The following is a description of a gene set: part of: Activation of GABAB receptors Reactome Pathway: Inhibition  of voltage gated Ca2+ channels via Gbeta/gamma subunits species: Homo sapiens GABA B receptors are coupled to Gproteins and function by increasing the K+ and decreasing the Ca2+ inside the cell. The increase in K+ increases the negative membrane potential of the cell thereby hyper polarizing the cell which inhibits the release of neurotransmitters. The decrease in Ca2+ also inhibits neurotransmitter in two ways; first by preventing the fusion of synaptic vesicles containing the neurotransmitter with the plasma membrane and second by decreasing the Ca2+ dependent recruitment of synaptic vesicles to the plasma membrane. In particular GABA B receptors inhibit voltage gated Ca2+ channels via the activity of Gbeta/Ggamma subunits of G proteins., and this is the list of marker genes: GNG13, GNG10, GNG2, GNG5, GNGT1, KCNJ6, GNB5, KCNJ5, KCNJ2, KCNJ9, GNG11, GABBR1 (NCBI Gene Id 2550), GNB1, KCNJ16, GNB4, KCNJ12, GNG8, GNB2, KCNJ4, KCNJ3, GNG7, GNGT2, GNG3, GNG12, GNB3, KCNJ10, GNG4, KCNJ15, GABBR2